The following is a description of a gene set: from publication Chen Y, Wang X (PMID 31504780) studied in species Mus musculus Mouse Gene Set: MIR_27B_5P Genes predicted to be targets of miRBase v22 microRNA mmu_miR_27b_5p in miRDB v6.0 with MirTarget v4 prediction scores > 80 (high confidence targets)., and this is the list of marker genes: Rbm39, Dsg1a, Bmt2, Parpbp, Eif2ak1, Ubtf, Srsf6, Azi2, Clptm1, Btbd16, Dcdc2a, Ttc28, Dcaf7, Erv3, 4930579G24Rik, Ccl20, Clint1, Dscaml1, Edar, Vcf2, Dsg1b, Glcci1, Krtap3-1, Msi2, Dcx, Rasgef1b, Zfp36l1, Arl16, Pwwp2a, Mier3, Kcnmb2, Ets1, Gmcl1, Dnajb4, Me1, Prkra, Dnaja1, Npr3, Marco, Prpsap2, Crebrf, Golga5